The following is a description of a gene set: electronically inferred by orthology from the curated human pathway part of: Signaling by ERBB2; Signaling by PTK6 This event has been computationally inferred from an event that has been demonstrated in another species.<p>The inference is based on the homology mapping from PANTHER. Briefly, reactions for which all involved PhysicalEntities (in input, output and catalyst) have a mapped orthologue/paralogue (for complexes at least 75% of components must have a mapping) are inferred to the other species. studied in species Mus musculus Reactome Pathway: ERBB2 Activates PTK6 Signaling, and this is the list of marker genes: Egfr, Btc, Erbb2, Nrg3, Erbb4